Given this list of marker genes Marf1, Fchsd2, Tshz3, Sbspon, Rora, Moap1, Zfp661, Acbd3, Sox6, N4bp1, Smpx, Cxcr5, Snca, Mertk, Unc5c, Cdc42ep3, H13, Hook3, Ramp1, Pgbd5, here is a description of the gene set: Genes predicted to be targets of miRBase v22 microRNA mmu_miR_1943_3p in miRDB v6.0 with MirTarget v4 prediction scores > 80 (high confidence targets). Mouse Gene Set: MIR_1943_3P studied in species Mus musculus from publication Chen Y, Wang X (PMID 31504780)